The following is a description of a gene set: Catalysis of the reaction: GTP + H2O = GDP + H+ + phosphate. Human Gene Set: GOMF_GTPASE_ACTIVITY studied in species Homo sapiens, and this is the list of marker genes: NUCB1, RRAS2, TBXA2R, RAPGEFL1, CPEB2, MADD, TUBB3, NUGGC, VPS9D1, RASA1, RAB33B, RCC1, RHOBTB1, VAV3, ASAP1, IQGAP2, ARHGAP29, PSD4, RANBP2, RASA4 (NCBI Gene Id 10156), GTPBP1, MYO9B, ARHGEF10, RAB37, PLXNB1, ABR, NF1, GNG3, RALGPS2, DLC1 (NCBI Gene Id 94517), RGS8, DENND1A, SYDE2, SEPTIN5, RASA3, RAB11B, RGS7, TUBB6, NGB, PLEKHG3, RAP1BL, TBC1D22A, ARHGEF40, EPS8L2, DENND2C, ADAP2, ARL4C, RGS11, TBC1D3E, PSD3, TBC1D21, SEPTIN12, ERRFI1, TBC1D10C, RHEB, TBCC, JUN, RGS2, ARFGAP3, RAB22A, TBC1D3D, NPRL3, GFM2, ARFRP1, RAPGEF5, SESN2, RTKN, ELMO1, SRGAP1, RHOB, RASGRP1, DOCK5, RABGAP1, ARHGAP45, STARD13, SEC23B, ATL2, RUNDC3A, PSD, RAB33A, PLEKHG5, TBC1D3B, RAP1GDS1, GNAT2, TBC1D3L, ARFGEF2 (ADP ribosylation factor guanine nucleotide exchange factor 2), SIPA1L1, MTG2, PTGIR, ARHGAP30, RABL3, GNG5, GDPGP1, LAMTOR3, TRIO, RASD2, PLCB1, RANBP10, TBC1D3F, PLCE1, RAB14, RAB8A, SIPA1, RAB44, RAC2, STXBP5L, RGS3, ARHGDIA, GSPT1, VAV2, ARHGAP22, ARHGEF4, EEF1B2, THG1L, GNAT3, TBC1D2B, ARHGDIB, DNAJA3, GBP1, SLC38A9, IQSEC2, NET1, RP2, ELMOD1, RAB18, TBC1D16, PLEKHG7, RHOU, GDI1, GNAT1, AKAP13, RHOD, RASGRF2, KRAS, ARHGAP4, ARHGAP26, EEF1A2, GNB5, ELMOD3, DIS3, GTPBP3, SBF2, ALS2, RACGAP1 (Rac GTPase activating protein 1), GCGR, RGPD4, DENND5B, RABL2A, RGS13, NTPCR, ARHGAP36, RAB39B, REM1, SH2D3C, TBC1D20, MFN2, GPSM1, RINL, ARFGEF1, PLEKHG2, EEF1A1P5, DOCK3, TRIM23, EPS8L1, IPO5, EGF, ARHGEF33, FGD4, RASGEF1B, GNAL, GPN3, RAB7A, WDR41, GTPBP4, RGPD1, LAMTOR4, RAB6C, RAB41, HPS1, LSG1, RIMS1, RAB7B, ARL1, RAB21, TAGAP, PLEKHG1, DNMBP, RRAD, DOCK6, RHOF, EPS8L3, STARD8, RAB9B, THY1, RHOBTB3, ARHGAP5, DOCK4, EIF5B, RAB35, ENTPD4, AGAP9, ARHGAP21, OCRL (NCBI Gene Id 4952), SEPTIN7, RND3, GCH1, SRGAP3, HRAS, ARHGAP27, FGD6, SMAP2, RASL10B, GMIP, ADRA2C, SERGEF, RGL1, OPA1, SWAP70, GPS2, LARS1, TBCK, EIF2B5, PSD2, CHN1, GBP6, ARHGEF37, SEPTIN14, ARHGEF28, GNAI2, RHEBL1, GNB1, AGAP1, GNAI3, RGL4, BCAR3 (BCAR3 adaptor protein, NSP family member), DIRAS3, TBC1D7, RANBP1, BMS1, SH2D3A, ARL6, ARL5A, RGS17, RND2, MTG1, ZNG1E, RAB19, ARL11, RIN3, ARHGAP11A, MMUT, RAB12, TUBB4B, RAB11A, GNL1, GNA14, RALA, RGS12, FGD3, RHOG, GNB3, CDC42, DNM1, SOS2 (SOS Ras/Rho guanine nucleotide exchange factor 2), RAB9A, FGD1, ARHGEF18, PLEKHG6, GARNL3, REM2, GIMAP7, GNA13, AGFG2, ARHGAP12, ALS2CL, ATL1, P2RY12 (purinergic receptor P2Y12), RABIF, GNB2, RASL10A, FAM13B, RAB40A, RABGAP1L, RIT1, RIC8A, ARHGEF2, TBC1D24, DOCK8, DEPDC5, GNA11, TBC1D19, RASGEF1C (NCBI Gene Id 255426), GPN1, RASL11B, DAB2IP, DEPDC1, ARHGAP33, DOCK9, AGAP2, RAB3B, IRGQ, ARHGAP19, NKIRAS1, DENND11, DENND1C, RALGPS1 (NCBI Gene Id 9649), ARHGEF7, TIAM2, CHML, RAB3GAP1, RAB43, ARHGAP32, DIRAS1, RALGAPB, RASD1, RGPD6, RAB4A, HBS1L, SBF1, SAR1A, ARHGAP6, SEPTIN6, PDGFRB, ADRA2A, EIF5, SYDE1, SH3BP5L (SH3 binding domain protein 5 like), RALB, RAB1B, MCF2L, MX1, TUBB1, RALGAPA1, RASGRP4, RAB29, ACAP2, RAP1A, IQSEC1, RIC1, EVI5, HACD3, ARF6, SGSM3, SMCR8, MYCBP2, ALDH1A1, DENND2B, ARHGAP42, BNIP2, SH3BP4, ITSN2, SEC61B, TUBB2B, ARHGEF39, GNG11, RAB39A, TBC1D3H, ARHGAP25, SEC23A, FAM13A, RIC8B, RASGRP3, SLIT2, IRGC, SGSM1 (small G protein signaling modulator 1), SRPRA, TBC1D5 (NCBI Gene Id 9779), C9orf72, TBC1D2, RGS4, MTSS2 (NCBI Gene Id 92154), DEPTOR, RASAL3, RERG, GPS1, DENND2D, RABEP1, SEPTIN1, FARP2, CYTH3, GNAZ, SEPTIN8, TBC1D3C, RASL12, ARHGEF3, MFN1, RASAL1, GTPBP10, HERC2, GAPVD1, EIF2B4, RAP2A, SMAP1, ARL16, RAB28, ARL2, DENND4B, RAPGEF6, HMGCR (3-hydroxy-3-methylglutaryl-CoA reductase), CCDC88C, TBC1D10A, RGS18, RGS21 (NCBI Gene Id 431704), KIAA1755, IPO7, ARFGAP1, IFT27, IRGM, TSR1, DOCK10 (NCBI Gene Id 9714), CCDC88A, TUBB, RND1, ELMOD2, LAMTOR2, TBCD, RASGEF1A, RIN2, TUBA1B, RAB1A, RAB30, DNAJC27 (NCBI Gene Id 51277), SEPTIN2, ACAP1, ASAP3 (NCBI Gene Id 80984), TBC1D1, TUFM, ABCE1, GNAS, ACAP3, RAB15, GNG10, RAB6B (RAB6B, member RAS oncogene family), ARL2BP, GNGT1, RHOH, EEF2, KALRN, GNA12, TUBB8B, HERC1, LLGL1, RAP2C, CRACR2A (NCBI Gene Id 84766), EFTUD2, RABEP2, HTR2B, KNDC1, RAPGEF3 (NCBI Gene Id 27105), RGP1, RASA2, SRP54, PLCG1, RASA4B, STXBP5, NLRP10, RGS16, RAB3IP, ARAP1, RGPD8, ADGRB3 (adhesion G protein-coupled receptor B3), RAB5C, FARP1, ARHGAP18, MCF2, ARHGEF1, ARHGAP1, DENND4A, SH3BP1, TBC1D10B, TBC1D9B, GIT2, TBC1D9, RNF112, EFL1, SPATA13, SIRPA, NUCB2, DENND3, GPSM3 (G protein signaling modulator 3), RAB1C, ATL3, EEFSEC, GRTP1, IQGAP3, ARRB1 (NCBI Gene Id 408), DNM1P34, ARL10, FGD5 (NCBI Gene Id 152273), RERGL, RHOQ, RANGRF, DNM1L (dynamin 1 like), GNGT2, IQGAP1, RHOT2, ARHGEF12 (NCBI Gene Id 55406), PREX1, RALGDS, RPGR, RAB26, ARHGEF25, ARHGEF10L, DOCK2, ARHGAP15, ARL4D, SOS1, RHOC, PREB, ARHGAP28, SYNGAP1 (NCBI Gene Id 8831), RAB10, GSPT2, MON1A, PCP2, CHN2, RAB40B, RAB23, GPN2, ARHGAP11B, IFT22, TBC1D30, DRG2, RANGAP1, TBC1D26, GIT1, RHOA, GPSM2, MYO9A, RAB36, RAB3A, LRRK2, RRAS, WAS, ARHGEF38, RASEF, ARHGAP23, EIF2B1, RAB3D, ARHGEF19, ARHGEF15, RRAGD, CYTH1, DNM2, GBP4, DENND5A, RASL11A, RAB5A, RRAGA, MTIF2, TPPP (NCBI Gene Id 11076), TBC1D3G, RAB40AL, RGS10, ARL5C, GNA15, PDE6D (phosphodiesterase 6D), GNAO1, SGSM2, ARHGEF16, VAV1, ECT2L, RRAGC, RGPD3, RGPD2, RAB2A, RIN1, GDI2, ARAP2, ARL3, TUBB2A, RGS1, TBC1D12, ARHGEF17, FGD2, ARAP3, ARL13A, RAB32, MRAS, RGS6, SEPTIN3, TBC1D8, GBP5, RAN, RAC1, RAPGEF1, GTPBP2, ADAP1, TBC1D17, TBC1D14, RGL2, ARHGAP8, MX2, ITSN1, ARF3, ENTPD7, AGAP11, NKIRAS2, SAR1B, RIT2, RGS5, EIF2B3, SRGAP2, ARHGEF26, MCF2L2, CPLANE2, FBXO8, ASAP2, ARL15, DEPDC1B, GRIPAP1, DENND6A, NRAS, TBC1D22B, ARHGAP9, ARHGEF5, RAB6D, GNL2, ARF5, AGAP6, TBC1D3K, ARHGAP31, DENND6B, EEF1D, ARL9, WASL, SEPTIN4, RAB3IL1, DENND1B, FRMD7, GEM, TUBB8, RAB3C, RALGAPA2, ARFGAP2 (NCBI Gene Id 84364), GNAQ, TUBB4A, RAPGEF2, ARL8B, TIAM1, RALBP1, AGAP7P, ARL17B, LLGL2, ARHGAP35, TBC1D3, TBC1D4, ARHGAP44, CHM, RCC1L, RGL3, NRP1, ARHGAP20, EIF2S3B, KRIT1, LAMTOR1, EIF2S3, RAB6A, AGAP3, RABGEF1, OPHN1, DEF6, RAB27B, TBC1D3I, CYTH2, ARF1, ARL4A, BCR, GFM1, RHOV, RAB20, RAB2B, TSC2, ITGB1BP1, NCKAP1L, ANKRD27, SEPTIN10, RAB34 (RAB34, member RAS oncogene family), ENTPD1, ARL13B, DOCK11, ARHGEF11, ABCA4, RCC2, RAB3GAP2, HPS4, RASGRP2, NPRL2, ARL5B, SIPA1L2, RAB8B, GBP2, ERAS, AGAP4, RABL2B, DENND2A, DOCK7, DOCK1, EVI5L, ARHGAP24, SIPA1L3, RCBTB2, PLEKHG4, ARHGAP17, RAP1GAP, RAB17, ARHGDIG, EEF1A1, RAB38, ARF4, PREX2, CDC42EP2, ECT2, IQSEC3, RGS19, TBC1D15, RASGRF1, RHOJ, MMAA, SH3BP5, RGS14, CDC42SE1, GRB2, CCZ1, RAB24, ARHGEF6, RGPD5 (RANBP2 like and GRIP domain containing 5), FLCN, GBF1, RAP1GAP2, RAB27A, RAB42, RAP1B, DENND10, RAB31, RAP2B, RAB4B (NCBI Gene Id 53916), GNG8, GBP7, RHOT1, RAB5B, OBSCN (obscurin, cytoskeletal calmodulin and titin-interacting RhoGEF), DIRAS2, ARHGEF9, AGFG1, EIF2B2, RGS9, ARL14, PLEKHG4B, ARHGAP39, LAMTOR5, RAC3, RASAL2, GBP3, TBC1D25, ARHGAP40, RAB13, RGS20, DENND4C, DNM3, GNAI1, TBC1D13, ARFGEF3, PLCD4, RAB25, RAB40C, RAPGEF4, USP6NL, RHOBTB2, ARL8A, AGAP5, NGEF, SEPTIN11, SEPTIN9 (septin 9), GUF1, DRG1, TBC1D8B, DDX3X, ADSS1, ARHGAP10, TNK2, RRAGB, CYTH4